The following is a description of a gene set: An immune response mediated by cells expressing specific receptors for antigens produced through a somatic diversification process, and allowing for an enhanced secondary response to subsequent exposures to the same antigen (immunological memory). Mouse Gene Set: GOBP_ADAPTIVE_IMMUNE_RESPONSE species: Mus musculus, and this is the list of marker genes: Cd27, Ighv1-81, Ighv13-2, Dlg1, Tnfrsf17, Kmt5b, Ifna15, Pdcd1, Slfn1, Foxj1, Gimap3 (NCBI Gene Id 83408), Aplf, Zp3, H2-Q1, Ighv1-50, H2-M10.2, Ighv8-2, H2-M9, Lgals1, Cd1d2, Cd3d, Stx7, Cracr2a, Gadd45g, H2-M10.3, Trim27, Zc3h12a (zinc finger CCCH type containing 12A), Pcyt1a, Ighv4-1, Ighv5-12-4, Igll1, Gm13276 (NCBI Gene Id 545649), Il18rap, Azgp1, Stx11, Btla, Il7r, Il17a (NCBI Gene Id 16171), Cd28, Supt6, Ndfip1 (NCBI Gene Id 71674), Cr2, Crtam, Nsd2, Tap1, Il27ra, Bmx, Ighd, Tarm1, Ighv1-23, Gm13283, Ighv5-4, Arg2, Il4, Rorc, Il2, Gm13271, Crlf2, Tnf, Rc3h1, Fgl1, Ighv14-1, Lig4, Icam1, Unc13d, Jak3, Rora, Notch1, Ceacam1, Mbl1, Ywhag, Socs5, Paxip1, Lta, Ccl20, Kdelr1, Cd274, Ifnk, Lax1, Anxa1, Was, Serping1, Gm13277, Ighv1-12, Cd244a, Cd8b1, 6030468B19Rik, Fcamr, Cd160, Ighv1-61 (immunoglobulin heavy variable 1-61), Mr1, H2-D1, Xrcc4 (X-ray repair complementing defective repair in Chinese hamster cells 4), H2-T24, Ighv1-66, Ppp3cb, Ighv11-1 (immunoglobulin heavy variable 11-1), C9, Nlrp10, Ifng, Hmces, Zfp683, Prkcd, C1s2, Ighv2-4, Ifna12, Ighv1-77, Traf2, Ighv8-8 (NCBI Gene Id 780938), Relb, Ighv1-58, Cd81, Zbtb7b, Il33, C1qbp, Myd88, Ighv6-7, Ighv1-54, Ighv14-3, Igha (immunoglobulin heavy constant alpha), Il27, Cx3cr1, Card9, Unc93b1, Ighv1-26, Ighv9-1, Mad2l2, Cd55b, Dbnl, Il23r, Cd79a, Fcer1a, Eif2ak4, Spn, Rif1, Nedd4, C2, Mcoln2, Tec, Sirt1, Ighv1-75, Sla2, Il18r1, Ifne, Cd79b, H60c, Orai1, Ighv3-5, C8b (complement component 8, beta polypeptide), C1qa (complement component 1, q subcomponent, alpha polypeptide), Il1r1, Ighv8-12, Ptprc, Klrd1, Nfkb2, Tyk2, Ephb2, Il4ra, Hpx, Mir326, Xcl1, Cd55, Ighv3-6, Vtcn1, Dpp4, Havcr2, Rab27a (RAB27A, member RAS oncogene family), Fbxo38, Ighv1-11, Stat4, Muc4, Opa1, Ighv7-3, Ighv1-67, Il17f, Rsad2, H2-DMb1, Ighv1-16, Ighv3-1, Fosl2, Ighv1-85, Raet1e, Cd1d1, Ighv2-2, Marchf8, Fcmr, Prkaa1, Itk, Traf6, Cd74, Pdcd1lg2, Igkv6-17, H2-M10.1, Klrk1, Phb1, Nckap1l, H2-Q10, Gata3, Arid5a, Pla2g4a, Exosc3, Cd24a, Ifna16, H2-T15, Ighv1-15, Mir301, Tap2, Sh2d1a, Prr7, Clec4g, Ighv1-63, Otub1 (OTU domain, ubiquitin aldehyde binding 1), Ighv1-24, Clec7a, Lime1, Ifnab, Ctla4, H2-T23, H2-M10.6, Foxp3, Eomes, Mill1, Ighv6-5, Il6, Treml4, Ly9, Bcl6, Iglc3, Ighv2-3, Masp2, Brd2 (bromodomain containing 2), Ifna5, Nbn, Fzd5 (NCBI Gene Id 98335), Ighg2b, Mfsd6, H2-K1, C4bp, Aire, Gzmb, Ighg2c, Ebag9, Tnfrsf1b, Tnfsf13b (tumor necrosis factor (ligand) superfamily, member 13b), Traf3ip2, H2-M5, BC037156, Lilrb4b, Gpr183, Ctsh, Ighv1-42, Ripk2, Ifna14, Hmgb1, Iglc2, C1ra, Igkv2-112, Jam3, Erap1, Ighv2-6-8, Txk, B2m, Cd70, Tnfrsf13c, Rnf8, Ighv9-4, Slc15a4, Gcnt3, Fcgr3, Sh2d1b1 (SH2 domain containing 1B1), Siglecg, Zp3r (NCBI Gene Id 98633), Csf2rb, Ighv1-31, Slc22a13, Gzmm, Pnp, Dusp10, Ighv10-3, Klhl22, Gm13272, Ighv1-76, Ighv2-6, Igkv9-120, Alcam, Ighv2-9-1, Tnfsf4, Serpinb9, Hprt1, Fgl2, Ighv6-6, Swap70, Akirin2, Batf, Sash3, C4b, Trp53bp1, Mir181b-1, Ighv1-39, Ptk2b (NCBI Gene Id 211703), Gm13275, Prkcq, Ighv12-3, Il12rb1, Lef1, Icosl, Jak2, P2rx7, Cd19, H2-T3, Mtor, Tnfrsf14, Parp3, Fgb, Trpm4, Hspd1, Ctnnbl1, C3ar1, Mif, Fcer1g, Ccl19, Bcl10 (NCBI Gene Id 99555), Irf1, Cd46, Btk, Ifna2, Clec4d, Ighv1-43, Il1rl1, Tnfrsf13b, Prdm1, H60b, Mef2c, Ifna13, Ripk3, Fadd, Cd40, Clec4n, H2-M11, Irf4, Cd44, Slc11a1, Ctsc, H2-Q4, Ighv6-4, Hfe, Clcf1, Ighv1-55, Nfkbiz, Ighv1-64, Ighv9-2, Ighv5-6, Emp2, Il1b, Pvr, Ighv9-3, Cd3e, Ighv1-5, Pou2f2, Skap1, Sema4a, Stard7, Il31ra, Il18, Msh2, Ighv1-78, Ighv8-6, Ascl2, Otud7b, Il9, Ighe, Ifna6, Cd247, Raet1d, Cd84, Il20rb, Ifna9, Pycard, Ephb6, Ighv5-16, Il17ra, Ighv1-4, 2410137M14Rik, Ighv1-53, Il12b (interleukin 12b), H2-M2, Ufl1, Ighv1-72, Adgre1, Prkcz, Fgg, Fga (fibrinogen alpha chain), Slamf6 (NCBI Gene Id 80894), Ifna7, Fut7, Ighv10-1, Myo1g, Ep300, Rnf19b, Prkd2, Fcgr2b, Ighv5-17, H2-Q7, Il23a, Lyst, Nfkbid, Rag1, Pms2, Cd69, Tmem98, Tnfrsf21, Tcirg1, Prkcb, Shld1, Nod2, Ung, Ighv3-8, Tfeb, Adcy7 (adenylate cyclase 7), Ahr, Bcl3, Sit1, Kdm5d, Tgfb1, Exo1, Il12a, C1rb, Vegfa, Tbx21, Pik3cd, Slamf1, Jchain, Trem2, C3, H2-T5, Ighv1-22, H2-M10.4, Loxl3, Tfe3, Pdia3, Il4i1, H2-M10.5, Aicda, Ighv1-56, Ifna11, Cd40lg, Klhl6, Ercc1, Ager, Iglc1, Samsn1, Ighv3-3, Cyrib, Ighv8-11, Themis, Sanbr, Lgals9, Ighv6-3, Smad7, Gimap5, H2-M3, Tnfaip3, Inpp5d, Serpina3g, C1qc, Il2rb, Sh2d1b2, Gapt, Dusp22, Tnfrsf11a (NCBI Gene Id 21934), H2-Ea, Il9r, Ada, Il6ra (NCBI Gene Id 16194), Zbtb1, Pirb, Adam17, Ighv3-4, Gba1, Ighv14-2, Shld3, Ighv1-80, Il25, Ifna1, Ighv1-84, Ighv2-5, Ulbp1, Dclre1c, Malt1, H2-T22, Ifna4, Ighv8-5, Serpinb9b, Msh6, Susd4, Nlrp3, Lat, Lamp3, Ighv8-4, Ighv11-2, Rc3h2, Hspa8 (NCBI Gene Id 69197), Cd80, Mpeg1, Jag1 (jagged 1), Hlx, Il13ra2, Ccr6, Ighv2-7, C1s1, Ptpn6, Fyn, Cfi, H2-M1, Enpp1, Csf2rb2, Cr1l, Tnfsf18, Lilrb4a, C8g, Ighv2-9, Pkn1, Ighv1-62-3, H2-Q6, Zap70, H2-Q2, Cd226, Mbl2, Cd3g, Rnf168, Mlh1, Atad5, Ighv7-1, Pag1, Igkv4-55, Vsir, Syk, Lat2, Pagr1a, Fcgr4 (NCBI Gene Id 320130), Fcrlb, Rnf125, Bach2, Ighv1-7, Hras, Ighv1-47, H2-DMa, Hc, Ighv16-1, Igkc, Map3k7, Ighv5-9, Dennd1b, Rftn1, Lag3, Cd4, Ighm, Cfh, C1rl, Mir873a, Ighv14-4, Tnfsf13, Ighg1, Stat6, Ighv1-34 (immunoglobulin heavy variable 1-34), Ighv1-49, Kmt5c, Mcoln1, Stat3, Slamf7, Il18bp, Igkv7-33, Ighv1-71, Entpd7, Ighv5-12, Ifnb1, Tfrc, Ighv8-9 (immunoglobulin heavy variable V8-9), Clec4a2, Irf7, Nectin2, Fcgr1, Slfn2, Kcnj8, Trat1, Ighg3, Cd8a, Gfus, Pf4 (platelet factor 4), Camk4, Ighv8-13, Crp, Ccr2, Cd7 (CD7 antigen), Ighv1-82, H2-T13, Prf1 (perforin 1 (pore forming protein)), Cdh17, C8a (NCBI Gene Id 230558), Ifnz, C1qb, Fcer2a, Fas, Tsc1, Cd86, Ccr7, Trem1, Trex1, Alox15, Shld2, Brd4, Exosc6, Otud5, Mir181b-2, Lyn, Csk, Arg1